The following is a description of a gene set: studied in species Mus musculus The transfer of electrons from NADH to ubiquinone that occurs during oxidative phosphorylation. Mouse Gene Set: GOBP_MITOCHONDRIAL_ELECTRON_TRANSPORT_NADH_TO_UBIQUINONE, and this is the list of marker genes: Dld, Ndufv1, Ndufb8 (NCBI Gene Id 67264), mt-Nd5, Pink1, Ndufb6 (NADH:ubiquinone oxidoreductase subunit B6), mt-Nd3, mt-Nd4, Ndufs1, Ndufs6, Ndufc2, Ndufs2, Ndufb9, Coq9, Ndufs3, Dnajc15, Iscu, mt-Nd6, Ndufa8, Ndufs8, Ndufa7, Ndufaf1, mt-Nd1, mt-Nd2, Ndufa11, Park7, Ndufa10, Bdnf, Ndufv2, Ndufs7